The following is a description of a gene set: Reactome Pathway: HDL assembly studied in species Homo sapiens HDL particles play a central role in the reverse transport of cholesterol, the process by which cholesterol in tissues other than the liver is returned to the liver for conversion to bile salts and excretion from the body and provided to tissues such as the adrenals and gonads for steroid hormone synthesis.<br>HDL particles are heterogeneous and can be fractionated into sub-populations based on their electrophoretic mobility, their density, or their content of various apolipoproteins. All HDL particles share two key features: they are assembled on a protein scaffold provided by apolipoprotein A-I (apoA-I), and they are recycled to allow a net flow of lipids from peripheral tissues to the liver and steroidogenic tissues while allowing apoA-I molecules to be re-used.<br>Here, the assembly of nascent (discoidal) HDL particles on newly synthesized apoA-I, a process that in the body occurs primarily in the liver, and the loading of discoidal HDL with additional lipid through interaction with cells carrying excess cholesterol (transformation to spherical HDL) are annotated. part of: Plasma lipoprotein assembly, and this is the list of marker genes: BMP1, PRKACG, ABCA1, ZDHHC8, A2M, PRKACA, PRKACB, APOA1